Given this list of marker genes Slc66a2, Chek1, Frrs1, Abracl, Npnt, Rrm2, Homer2, Cd82, Lcn2, Skp1, Tceal9, Kcnn4, Wfdc18, Tpd52, Id2, Dok1, Acsl4, Plet1, Etv1, Dsg2, here is a description of the gene set: from publication Landis MD, Seachrist DD, Montañez-Wiscovich ME, Danielpour D, Keri RA (PMID 15897883) Up-regulated genes from top genes out of the 324-gene signature identified in the pre-neoplastic tissue adjacent to the mammary tumors induced by transgenic expression of ERBB2. Mouse Gene Set: LANDIS_ERBB2_BREAST_PRENEOPLASTIC_UP Upregulation of HER2/ErbB2/Neu occurs in 15-30% of human breast cancers and correlates with poor prognosis. Identification of ErbB2/Neu transcriptional targets should facilitate development of novel therapeutic approaches. Development of breast cancer is a multistep process; thus, to identify the transcriptomes associated with different stages of progression of tumorigenesis, we compared expression profiles of mammary tumors and preneoplastic mammary tissue from MMTV-Neu transgenic mice to expression profiles of wild-type mammary glands using Affymetrix microarrays. We identified 324 candidate genes that were unique to ErbB2/Neu-induced tumors relative to normal mammary gland tissue from wild-type controls. Expression of a subset of these genes (82) was also changed in the preneoplastic mammary glands compared to wild-type controls, indicating that they may play a pivotal role during early events of ErbB2/Neu-initiated mammary tumorigenesis. Further analysis of the microarray data revealed that expression of several known transforming growth factor (TGF)-beta target genes was altered, suggesting that the TGF-beta signaling cascade is downregulated in ErbB2/Neu-induced tumors. Western blot analysis for TGF-beta-Receptor-I/ALK5 and immunohistochemistry for TGF-beta-Receptor-I/ALK5 and phosphorylated/activated Smad2 confirmed that the Smad-dependent TGF-beta signaling cascade was inactive in these tumors. Although absent in most of the tumor, phosphorylated Smad2 was present in the periphery of tumors. Interestingly, presence of phosphorylated/activated Smad2 correlated with expression of Activin-Receptor-IB/ALK4, suggesting that although Smad-dependent TGF-beta signaling is absent in ErbB2/Neu-induced tumors, Activin signaling may be active at the leading edge of these tumors. Cumulatively, these data indicate that the TGF-beta pathway is intrinsically suppressed in ErbB2/Neu tumors via a mechanism involving loss of TGF-beta-Receptor-I/ALK5. studied in species Mus musculus